Given this list of marker genes IL10, DAG1, CASQ1, FBXO32, PIK3CA, ACTN3, HDAC4, SCN5A, DRD2, MYOG, CAT, here is a description of the gene set: Human Gene Set: GOBP_RESPONSE_TO_INACTIVITY species: Homo sapiens Any process that results in a change in state or activity of a cell or an organism (in terms of movement, secretion, enzyme production, gene expression, etc.) as a result of an inactivity stimulus.